Given this list of marker genes NGFR, CDK5RAP3, EDN1, F2, CDK1, SESN2, TFRC, CACNB4, SMAD3, PARP9, FLNA, NPM1, SRC, LEP, RBM22, CCT5, GLIS2, EP300, ORMDL3, FYN (FYN proto-oncogene, Src family tyrosine kinase), HCLS1, MAPK14, NMD3, PRKCD (NCBI Gene Id 5580), SMO, BMP4, CCT2, PINX1, WWTR1, LIMK2, DMAP1, CDKN2A, XBP1, LAMTOR5, FERMT2, JAK2, CDH1, GLI3, TRIM8, TERT, LARP7, AKT1, IPO5, CCT8, HSP90AA1, TGFB2, PIK3R1, TYK2, PYHIN1, INS, ZC3H12A, TRIM28, RAN, TESK1, PLK1, SHH, DTX3L, PPP3CB, CCT4, HDAC3, TPR, CCT3 (NCBI Gene Id 7203), ZPR1, CHP2, HYAL2, TGFB1, PARP1, JAK1, PIK3R2, CREBBP, CARD10, MCRS1, YAP1, MEPCE, UBR5, EFCAB7, PARK7, KAT7, JUP, TARDBP, PSEN1, TCF7L2, CD2AP, ZIC1, BAG3, TCP1, MAVS, PRKD1, EIF2AK3, IFNG, CCT6A, CCT7, STK11, IPO7, ECT2, here is a description of the gene set: Any process that activates or increases the frequency, rate or extent of protein localization to nucleus. Human Gene Set: GOBP_POSITIVE_REGULATION_OF_PROTEIN_LOCALIZATION_TO_NUCLEUS studied in species Homo sapiens